The following is a description of a gene set: Genes predicted to be targets of miRBase v22 microRNA hsa-miR-6784-3p in miRDB v6.0 with MirTarget v4 prediction scores > 80 (high confidence targets). species: Homo sapiens Human Gene Set: MIR6784_3P from publication Chen Y, Wang X (PMID 31504780), and this is the list of marker genes: KCNB1 (NCBI Gene Id 3745), OOSP2, IDS, FBXL5, ITGAV, SYNPO2, CCNT1, TMEM121B, CADM1, EPHA8, RORA, ZZZ3, PLOD1, BBS1 (NCBI Gene Id 79702), ZNF322, PPM1A, ENDOV, OSBPL7, POGLUT1, ZKSCAN2, SBNO1, ZFHX4, MAFB, EGFLAM, ZNF35, SDK2, ZBTB33 (NCBI Gene Id 10009), XKRX, ZNF189, ITPRID2, GORASP2 (NCBI Gene Id 26003), HAL, DLG3, OTUD3, TRIM10, STT3A, CDYL, SPHKAP, TNFAIP8L3, LCOR, PLCXD2